The following is a description of a gene set: species: Homo sapiens Human Gene Set: HP_BROAD_ISCHIA Broad ischia Increased width of the ischium, which forms the lower and back part of the hip bone., and this is the list of marker genes: COL11A1, ALG9, LIFR, TMEM53, EXTL3